Given this list of marker genes KCTD18, EIF5A, NBR1, CFAP184, SRSF12, TMEM42, SLC26A5, NBPF3, COL19A1, ADAM17, CALM1, SMAD7, HNRNPA0, RNF13, THBS4, OSR1, HNRNPK, RHOXF2, NEK6, KLHDC1, MED13L, ZBED5, RNF166, DRD1, MRFAP1, TRDN, SCRT1, MSR1, RHOXF2B, SPIN3 (NCBI Gene Id 169981), RER1, WIF1, DCK, TNKS2, KIAA1586, MDGA2, BAG5, NEXMIF, here is a description of the gene set: Genes predicted to be targets of miRBase v22 microRNA hsa-miR-424-3p in miRDB v6.0 with MirTarget v4 prediction scores > 80 (high confidence targets). species: Homo sapiens from publication Chen Y, Wang X (PMID 31504780) Human Gene Set: MIR424_3P